The following is a description of a gene set: Genes up-regulated in T cells treated with IL21: 6h versus 24h. from publication Kwon H, Thierry-Mieg D, Thierry-Mieg J, Kim HP, Oh J, Tunyaplin C, Carotta S, Donovan CE, Goldman ML, Tailor P, Ozato K, Levy DE, Nutt SL, Calame K, Leonard WJ (PMID 20064451) Interleukin-21 (IL-21) is a pleiotropic cytokine that induces expression of transcription factor BLIMP1 (encoded by Prdm1), which regulates plasma cell differentiation and T cell homeostasis. We identified an IL-21 response element downstream of Prdm1 that binds the transcription factors STAT3 and IRF4, which are required for optimal Prdm1 expression. Genome-wide ChIP-Seq mapping of STAT3- and IRF4-binding sites showed that most regions with IL-21-induced STAT3 binding also bound IRF4 in vivo, and furthermore, revealed that the noncanonical TTCnnnTAA GAS motif critical in Prdm1 was broadly used for STAT3 binding. Comparing genome-wide expression array data to binding sites revealed that most IL-21-regulated genes were associated with combined STAT3-IRF4 sites rather than pure STAT3 sites. Correspondingly, ChIP-Seq analysis of Irf4_/_ T cells showed greatly diminished STAT3 binding after IL-21 treatment, and Irf4_/_ mice showed impaired IL- 21-induced Tfh cell differentiation in vivo. These results reveal broad cooperative gene regulation by STAT3 and IRF4. species: Homo sapiens Human Gene Set: GSE19198_6H_VS_24H_IL21_TREATED_TCELL_UP, and this is the list of marker genes: CDH1, VILL, PLEK, CYTL1, HMG20B, G0S2, KCNN4, RAPGEF3, ITGA6, MANF, NDRG2, GPT2, ACTN1, SLC8A1 (solute carrier family 8 member A1), BID, PPP1R16A, EHF, NFAM1, INTS6L, TMED3, OLR1, SIGLEC17P, ARL6IP5, GM2A, ABCC3, APOL2, CCL17, DNAJC5B, KCNAB1, FOLR3, TOR3A, SOX4, RAB11FIP4, EDN1, MICALL2, BANP, MFSD6, ISOC1, CATSPER1, FRMD3, TMEM223, KCNK13, PPP1R14A, GUCY1B1, SPATA12 (NCBI Gene Id 353324), AKR1C3, SFT2D2 (SFT2 domain containing 2), HLA-G, LINC00622, CDK14, ANXA11, NFKBIE, NR1H3, NR4A3, GALNT18, PLBD1 (NCBI Gene Id 79887), ITGAL (integrin subunit alpha L), CD82, ATF3, GSTK1, PLPP5, TNFSF13B, HBEGF, SYTL1 (synaptotagmin like 1), ARAP3, SDF2L1, SLC7A11, CD40, SLC25A35, PLAUR, TXNRD1, AFTPH (aftiphilin), PDLIM7, TUBB6, ERLEC1, ZSCAN16, CYP27B1, SLC9A7, LY75, PLCB1, CHST7, FGD5, SERPINB9P1, RAB10, MIR3142HG, ADGRG2, TMEM50B, APOC2, SYT11, CCR7, TSPAN33, SH2D3C, LGALS2 (galectin 2), EGR2, GPAT3, CCDC18, BTN3A1, CDK5RAP1 (NCBI Gene Id 51654), TNFSF14, BTG3, EPHB6, SNAI3, RAP1GAP, HCAR3, SLC29A3, SERF1A, IL2RG, RHOQ, CCL5, LPCAT4, MYDGF (myeloid derived growth factor), PRR4, CD83, APOL3, C18orf32, SSR3, ICMT, C1orf115, ADO, S100P, MGST1, HSD11B1, CKAP4, TMEM91, MAP4K5, NDUFB9, SPCS1, CD1B, ATP6V0D2, CDS1, SLAMF7, SERPINE1, PLCD1, CEBPB, HLA-J, TP53I13, BPI, HLA-F, ALDH5A1, CYP1B1, GORAB, CCNA1, SDSL, BIRC3, ATP1B1, ALG8, METTL1, NARS1, PDP2, PDIA3, CD86, LRRFIP2, TRAF1, HTRA4, PKIG, TIMP3, DIPK1A, DNAJC10, SLC27A3, PHLDA3, UBA7, ADAM12, NCF2, NUP210, GALNS, SRD5A3, MYCL, BSCL2, WNT5A, LMLN, TYW5, PLXDC2, HILPDA, MBOAT7, SGCB, EMC4 (NCBI Gene Id 51234), ZGLP1, ZNF576, PSME2 (proteasome activator subunit 2), RAB5IF, TMEM52B, ZFYVE16, KDELR2, PHPT1, ITPRIP, ZDHHC3, PSTPIP1, MARCKSL1, CRELD2, SLC44A2, PRKD3, TMEM131L, BCAR3, SLC25A29, CPEB1, PPT1, SPINK1, DBH-AS1, BCL11A